Given this list of marker genes MTMR7, SYNJ1, MTMR14, INPP5F, MTM1, MTMR8, FIG4, MTMR3, MTMR6, MTMR11, MTMR4 (myotubularin related protein 4), MTMR1, MTMR12, SACM1L, SYNJ2, MTMR10, MTMR2, PTEN, here is a description of the gene set: Catalysis of the reaction: phosphatidyl-1D-myo-inositol monophosphate + H2O = phosphatidylinositol + phosphate. Human Gene Set: GOMF_PHOSPHATIDYLINOSITOL_MONOPHOSPHATE_PHOSPHATASE_ACTIVITY studied in species Homo sapiens